Given this list of marker genes NEK1, IHH, TRIP11, RAD21, EVC2 (EvC ciliary complex subunit 2), RMRP, TRPS1, GDF5 (growth differentiation factor 5), SRCAP, ATR, MRPS28, EVC, IFT52, BGN, COG4, GPX4 (glutathione peroxidase 4, NCBI Gene Id 2879), MIR140 (NCBI Gene Id 406932), IFT140, NPR2, FLNA, FGFR3, EIF2AK3, KIF15, RUNX2, COL2A1, IFT172 (NCBI Gene Id 26160), EXT1, DYM (NCBI Gene Id 54808), MIA3, PRKAR1A, TRPV4, here is a description of the gene set: Human Gene Set: HP_CONE_SHAPED_EPIPHYSES_OF_THE_PHALANGES_OF_THE_HAND A cone-shaped appearance of the epiphyses of the fingers of the hand, producing a 'ball-in-a-socket' appearance. The related entity 'angel-shaped' epiphysis refers to a pronounced cone-shaped epiphysis in combination with a pseudoepiphysis at the distal end of a phalanx. Cone-shaped epiphyses of the phalanges of the hand studied in species Homo sapiens